Given this list of marker genes FBXO40, RPP38, DIRAS1, SPTB, GRIN2B, DOCK8-AS1, TRMT10A, SYNPO2L, AKR1B1, SMPX, RASD2, RAP2C, FBXW11, PTCH1, GYG1, ATF3, GPBP1L1, H2BC1, AQP1, ZNF516-DT, DGKI, TEF, KY, NDP, DZIP1L, TMEM182, ST6GALNAC5, KLHL40, EXTL1, ADRA1A, ARAP2 (NCBI Gene Id 23278), MYOM2, GPR153, CPT1B, ARR3, SLC2A4, SIPA1L1, TNNI3K, NEXN-AS1, HIVEP1, EPHA7, TFIP11, CARNMT1, TNNI1, SOX5, TRIM33, COL8A1, NPNT, CELF4, NR0B2, KLHL41, ABRA, PYY2, CACNA2D3, PACS1, ARPP21, LBX1 (NCBI Gene Id 10660), LINC00310, MFGE8, ZBTB18, KCNN1, PCBP2, ASB16, LZTS2, ATP1A2, RPP38-DT, TNNC1, KTN1, RGS3, FGF12, FOXP1, SLC32A1, CKMT2, ESAM, HOXB4, MEOX2, ELAVL4, ATP1B2, IKZF3, HJV, SLC9A5, CLCN1, RASGRP3, ARHGEF38, IGSF9B, RALY, NOG, RASGRF1, CSRP3, MEF2C, MYOCD, SPACA9, ITGB3BP, FITM1, GRK7, LYN, GNB4, GABRB3, C10orf71, JCHAIN, TNNC2, XK, EYA1, PPP1R3A, NCAN, CA7, AMMECR1, ZHX2, CNPY2, RETREG1, CLDN14, IRS1, CCN2, CNTN1, CASQ1, TCEA3, TNNI2, NREP, AK8, ART5, HS3ST5, TYRO3, AMPD1, SIK2, CKM, MACO1, S100A4 (S100 calcium binding protein A4), H3C1, PPP1R3D, MLLT3, ACTC1, POU4F2, MIEF2, RBMS3, SIK3, MYL1, LINC01597, S1PR1, PPP2R3A, PCMTD1, SLC25A4, RASGEF1B, THAP12, ZNF362, ADCY2 (NCBI Gene Id 254679), TNNT2, SMARCA1, ALPK2, TMEM71, ARMCX6, ZFAND5, KRT222, NELL2, BNC2, HPGD, CUX1, RIPOR1, KLHDC8B, LRRC39, ZRSR2, DMD, MYL2, CPEB4, HAPLN1, PYY, TP63, RHOBTB1, ESR1, TIMP2, CASQ2, CAPN3, ITGA7, POU4F1, HDAC9, PPP2R2A, NBEA, LARS1, COL13A1, BCL9L, PMEPA1, DLL4, PPARGC1A (PPARG coactivator 1 alpha), RCOR1, ADAM11, PAK6, SV2A (synaptic vesicle glycoprotein 2A), KCNQ5, ESRRG, WFDC1, TBPL1, NFAT5, LUZP1, HDAC7, SLAMF1, PLAGL2, CAMK1, RFX4, ADAM23, ZNF385B, ADAMTS12, USP2 (NCBI Gene Id 9099), DLG2, TRDN, ARHGAP26, RBFOX1, NR4A1, VXN, NR2F1, CRTAP, JUN, TPM2, SUPT4H1, MRPS23, POFUT1, H4C1, MYOZ2, H2AC1, TSC22D1, NDRG2, KCNJ9, SLC8A3, SCAI, KPNA3, MAFA, PRMT3, TWIST1, GPC4, ATP2A3, CACNG3, SMARCA2 (SWI/SNF related, matrix associated, actin dependent regulator of chromatin, subfamily a, member 2), FBXL22, BMAL1, GABRB2, PLEKHA6, GPR27, CASK, STAC, here is a description of the gene set: studied in species Homo sapiens Human Gene Set: MEF2_02 Genes having at least one occurrence of the motif NNNNNNKCTAWAAATAGMNNNN in the regions spanning 4 kb centered on their transcription starting sites. This matches the transcription factor binding site V$MEF2_02 (v7.4 TRANSFAC).